The following is a description of a gene set: species: Homo sapiens Human Gene Set: chr20q13, and this is the list of marker genes: SPINT3, RBPJL, TNFRSF6B, RPL37AP1, MIR645, KCNB1, R3HDML, RPL5P2, IFT52, ZNF840P, APCDD1L-DT, EPPIN, MATN4, MMP9, CASS4 (NCBI Gene Id 57091), SLCO4A1, RN7SL443P, LINC01056, STMN3, STAU1, WFDC13, FITM2, TTPAL, MIR3195, LIME1, RNU6-147P, PCMTD2, CSE1L-DT, RBM38-AS1, ENSG00000237464, SLC2A10, ADNP-AS1, CEBPB-AS1, PTMAP6, OGFR, ZNF335, ENSG00000290777, NPBWR2, RPS2P54, RNU6-1146P, LINC00494, RPL39P39, RPL13P14, BCAS4, GAPDHP54, ENSG00000291000 (NCBI Gene Id 101929863), NKAIN4 (sodium/potassium transporting ATPase interacting 4), GCNT7, ARFGEF2, ZNF217 (zinc finger protein 217), KCNQ2-AS1 (KCNQ2 antisense RNA 1), ENSG00000230226, MRPS16P2, MIR3616, UBE2V1, PPDPF (NCBI Gene Id 79144), PIGT, MIR941-4, RNU6-497P, MIR1-1, SLC17A9, RN7SKP184, WFDC2, SLPI, CTSZ, SEMG1, MIR3617, RNU6-563P (RNA, U6 small nuclear 563, pseudogene), RPL7P3, APCDD1L, VAPB, MIR3194, PEDS1-UBE2V1, SNRPFP1, MIR4756, MIR4758, NEURL2, NCOA3, C20orf181, ENSG00000309405 (NCBI Gene Id 124904919), NELFCD, OCSTAMP, PLTP, LINC01440, SRSF6, ZMYND8, PTGIS, RBBP8NL, ATP9A, COL9A3 (collagen type IX alpha 3 chain), RNA5SP487, CBLN4, ATP5F1E, RNU6-347P, ENSG00000304909, PTPRT-DT, HNF4A-AS1, UCKL1-AS1, RNA5SP486, ARFGAP1, RPSAP1, SPATA2, KCNS1, HNRNPA1P3, RNU7-6P, RPS21, MTG2, CD40, HELZ2, SNX21, ENSG00000298888, RN7SL666P, HAR1B, RNU1-134P, MIR6813, SGK2, RN7SL170P, LINC01524 (NCBI Gene Id 101927700), TP53RK-DT, KCNQ2, MIR296, R3HDML-AS1, RIPOR3-AS1, SNORD12B, RPS21-DT, MOCS3, OSBPL2, LINC01273, GLYR1P1, ENSG00000306557, RPL13P2, PPP1R3D, HSPD1P19, SCREEM1 (NCBI Gene Id 105372654), PI3, ZNF334 (NCBI Gene Id 55713, zinc finger protein 334), WFDC11, ZNF831, ARF4P2, RN7SL197P, RBM38, MHENCR, RIPOR3, LAMA5-AS1, RN7SL636P, GMEB2, SLC12A5, CSTF1, CCNB1IP1P2, FAM217B, HMGB1P1, MRPS33P4, GID8, WFDC3, MIR941-2, KRT18P4, MYBL2, MKRN7P, FLJ16779, SYS1, MIR4325, RN7SKP33, RNU6-639P, TFAP2C, LINC00659, HSPD1P21, EYA2, NTSR1, PRELID3B, LINC01711, RPL27AP, RTEL1-TNFRSF6B, HNF4A, PKIG, PMEPA1, FAM210B, RIMS4, SPINT4, LINC01754, YTHDF1, LINC01523, PPIAP21, IQSEC3P3, RNU7-144P, WFDC5, SPINT5P, MIR3196, ZNFX1, SPO11, COL20A1, MIR1302-5, ZFAS1, LINC01429, SRMP1, CCN5, RPL36P2, WFDC12, COX6CP2, CDH4, TAF4, JPH2, LINC02970, PTK6, CDH22, MIR133A2, ERP29P1, SEMG2, DDX27, ENSG00000310298, RNU7-92P, PPP4R1L, SDC4, LINC00686, CSE1L, CDH26, KCNG1, CRMA, TP53TG5, FAM209B, PELATON (NCBI Gene Id 100508225), NFATC2, RNF114, SERINC3, ADNP, MIR4533, ZSWIM1, SUMO1P1, SS18L1, TPD52L2, TCEA2, TOMM34, RPS2P7, PPIAP10, MIR1914, FAM209A, MYT1, CEBPB, LINC01620 (long intergenic non-protein coding RNA 1620), STK4-DT, TRERNA1, FNDC11, GDAP1L1 (NCBI Gene Id 93987), ZSWIM3, ZFP64, PEDS1, IL9RP5, PTPRT (NCBI Gene Id 11122), SULF2, SNORD12, DPM1, RN7SL672P, ZNF663P, SLC9A8, PCIF1 (NCBI Gene Id 63935), ENSG00000273828, LINC01275, SYCP2, GNAS, NPEPL1, EDN3, SAMD10, RPL39P, SRMS, RNU6-919P, RNU7-173P, SLC12A5-AS1, PRPF6, SPATA25, SOX18, NDUFB4P10, ENSG00000179253, MIR646HG, LINC01522, TNNC2, SLC13A3, WFDC6, TUBB1 (tubulin beta 1 class VI), SYS1-DBNDD2, PFDN4, ENSG00000231119, TMSB4XP6, MIR298, YWHAB, SLC35C2, PHACTR3-AS1, CHRNA4, NCOA5, EPPIN-WFDC6, HAR1A, ENSG00000306877, CYP24A1, BHLHE23, RNU7-14P, RGS19, WFDC8, ARPC3P1, RAB22A, SLCO4A1-AS2, ENSG00000287478, PABPC1L, PTPN1, ENSG00000288946, RNU6-743P, LAMA5, ZNF217-AS1, PIEZO1P2, ABHD16B, SNAI1, RPL36P1, CTSA, ENSG00000283078, FTLP1, MIR4326, RNU6-1251P, NKILA, RPL35AP, RTEL1, BMP7, PGBD4P2, OGFR-AS1, PSMA7, ENSG00000300800, RPL12P4, LINC01718, WFDC9, BIRC7 (NCBI Gene Id 79444), EYA2-AS1, TCFL5, SLCO4A1-AS1, DNAJC5, ENSG00000308438, ENSG00000259723, ADRM1, MIR941-1, L3MBTL1, RPL27AP9 (NCBI Gene Id 133039967), MIR548AG2, PARD6B, DNTTIP1, ENSG00000277270, LINC01749, OPRL1, ENSG00000252193, SNAP23P1, MIR124-3, MIR647, MTCO2P1, ACOT8, CICP4, KCNK15-AS1, ZBP1, C20orf204, LKAAEAR1, GNAS-AS1, SALL4, LINC03079, B4GALT5, MIR941-3, ZGPAT, AURKA, MC3R, LINC01441 (long intergenic non-protein coding RNA 1441), MIR646, RNU7-141P, RTF2, ENSG00000304817, RNU6-929P, ENSG00000233017, PHACTR3, MIR6812, DPH3P1, SNORD12C, RAE1, HRH3, SLC2A4RG, BMP7-AS1, ZNF512B, EIF4EBP2P1, GTSF1L, WFDC10B (WAP four-disulfide core domain 10B), STX16-NPEPL1, DBNDD2, RNU6ATAC38P, ARFRP1, LINC01716, LINC00029, ANKRD60, RPS4XP3, CABLES2, LSM14B, CTCFL, RNU6-994P, ADA, STK4, ENSG00000267882, GATA5, ENSG00000306635, ENSG00000302965, ZBTB46, OSER1-DT, PIEZO1P1, WFDC10A, TP53RK, LINC01271, DOK5, PREX1, LINC01728, MIR1257, ELMO2, ENSG00000306634, LINC01742, LINC01270, ZBTB46-AS1, ZBTB46-AS2, BCAS1, MIR3646, EEF1A2, RPL17P48, CIMIP1, MTND1P9 (MT-ND1 pseudogene 9), ENSG00000203900, OSER1, RNU4ATAC7P, MRGBP (NCBI Gene Id 55257, MRG domain binding protein), MIR1-1HG, MIR941-5, PCK1, DIDO1, KCNK15, RNA5SP485, ENSG00000299708, RPL29P35, PSMD10P1, TOX2, TSHZ2, UCKL1, STX16, UBE2C (ubiquitin conjugating enzyme E2 C)